The following is a description of a gene set: Any process that modulates the pH of the lysosomal lumen, measured by the concentration of the hydrogen ion. Human Gene Set: GOBP_REGULATION_OF_LYSOSOMAL_LUMEN_PH species: Homo sapiens, and this is the list of marker genes: TMEM165, TMEM199, TCIRG1, CLN3, ATP6V1H, OCA2, ATP6V1A, CLN5, ATP6V1D, CREG1, GRN, ATP6V1F, LRRK2, TASL, CLN6, CCDC115, VPS33A (VPS33A core subunit of CORVET and HOPS complexes), TMEM9, RNASEK, ATP6AP1, PPT1, ATP6AP2, ATP6V0B, TMEM106B (NCBI Gene Id 54664), ATP6V0C, TMEM175, ATP6V0A1, SNAPIN, LAMP1, SLC45A2, SPNS1, LAMP2 (NCBI Gene Id 3920)